Given this list of marker genes Rsad2, Colec12, Hmgb1, Zdhhc3, Ppt1, Tlr13, Scimp, Cd86, Treml4, Epg5 (NCBI Gene Id 71423), Peli1, Rnf170, Rab7b, Src, Cd300ld3, Irf2, Washc4, Nr1h4, Tnf, Ptprs, Irf1, Tlr9, Tnip2, Oas1e, Ptpn22, Gramd4, Tirap, Oas1g, Tlr7, Tlr3, Tnfaip3, Tasl, Oas1b, D1Pas1, Slc15a4, Myd88 (myeloid differentiation primary response gene 88), Oas1f, Tlr8, Rtn4, Hcfc2, F2rl1, Ddx3x, Cav1, Ticam1, Pik3ap1, Oas1h, Flot1, Oas1d, Oas1a, Oas1c, Rftn1, Ubqln1, Unc93b1, Trim3, Havcr2, Wdfy1, here is a description of the gene set: species: Mus musculus The series of molecular signals initiated by a ligand binding to an endolysosomal pattern recognition receptor (PRR) of the toll-like family. PRRs bind pathogen-associated molecular pattern (PAMPs), structures conserved among microbial species. Mouse Gene Set: GOBP_ENDOLYSOSOMAL_TOLL_LIKE_RECEPTOR_SIGNALING_PATHWAY